Given this list of marker genes IL27RA, MRPS25 (mitochondrial ribosomal protein S25), EXT2, VPS36, DACH2, NARF, ST3GAL1, CRNKL1 (crooked neck pre-mRNA splicing factor 1), DHX29, PPME1, DCUN1D2, ETV6, SYT11, CSK, SYS1, ZNF280D, CXCR3, PRKAR2A, CORO1A, ARHGEF6, CNN2, VWA5A, ARF1, PAFAH2 (platelet activating factor acetylhydrolase 2), SENP7, CYP11A1, CTSC (NCBI Gene Id 50958), RAB4B, PSMD6, ROMO1, HOPX, ARHGAP29, SRSF7, FGGY, BCCIP, PPP2R5A, COX17, TMEM158, EI24, GNG2, CTSD (cathepsin D), GIMAP7 (NCBI Gene Id 168537), MAPK11, DNAH8, CLDND1, INPP5B, PSMA3, GGT1, S100A6, HIC1, MCTP2, TLR1, ADCY6, HYPK, GPM6B, ENTR1, TALDO1, ZFP36L1, MRPL51 (mitochondrial ribosomal protein L51), STAT1, BBLN, TRIB2, POU2AF1, GTF3C6, SPICE1, ECSIT, CTSW, UQCC2, ELAVL1, ATXN7L3B, ATP2A2, ECM1, FAM78A, PICALM, MRPL52, PFN1, FOXO4, DNAJA1, TMEM238, ECH1 (enoyl-CoA hydratase 1), TOP1, ATP6V1H, ITPKB, PRPF38B, HACD1, CDC42EP3, DBNL, GPSM3, KPNA2, METTL3, TRPV2, ARPC5L, HDAC6 (NCBI Gene Id 100820762), FAM98A, DMTF1, TPRG1L, PNN, VPS45, SCAMP3, MGRN1, ACTN1, SLCO4A1, RFK, GATD3, NISCH, SSNA1, CETN3, TUBB4B, RRAS2, GBA1, RPS6KA1, PKP3, SELPLG, SRSF6, KDM5C, EDEM3, HSDL2, ATG3, ERH, PPDPF, HMMR, GALNT6, CIC, HECTD3, CEP55, ULK2, GRAMD4, BICD2, NEAT1, RASSF2, ITGB1BP1, ESYT1, DSTN, TNFRSF1A, KBTBD11, UBA1, FAM120B, ZNF207, MRS2, PIGQ, PSD4, GLRX2, NDRG3, UBL4A, SLA, SIPA1L1, APP, SMARCD2 (SWI/SNF related, matrix associated, actin dependent regulator of chromatin, subfamily d, member 2), NEMF, TRAF5, PDIA6, SUGT1, SSBP4, RBX1, NXF1, DNAJB11, ENTPD5, SMAP2, CYB5A, S100A11, MTCH2, THY1 (Thy-1 cell surface antigen), SLC30A5, CYB561A3, PLAC8, CHD3, EXOSC8, XPO1, MTF2, MID1IP1 (NCBI Gene Id 58526), SOAT1, STIP1, GDI1, GPR132, AP4S1, ZNF467, CDC23, SLC30A4, TMEM126A, L1CAM, PROS1, TGFB3, VSIR, RFX1, EMG1, MTREX, TIA1, MRPS21, IL12RB2, LAMA5, ANXA5, HSPA1B (heat shock protein family A (Hsp70) member 1B), CCR5, TMEM147, NKG7, PTPRCAP, GRB2, KCNN4, AKT2, CDR2, here is a description of the gene set: Human Gene Set: GSE22601_IMMATURE_CD4_SINGLE_POSITIVE_VS_CD4_SINGLE_POSITIVE_THYMOCYTE_UP Genes up-regulated in CD4 single positive cells: immature versus thymocytes. T cells develop from progenitors that migrate from the bone marrow into the thymus. Thymocytes are subdivided roughly as being double negative (DN), double positive (DP), or single positive (SP), based on the expression of the CD4 and CD8 coreceptors. The DN stage is heterogeneous and can be subdivided into four distinct subsets in mice based on the expression of CD44 and CD25. In human, three distinct DN stages can be recognized: a CD34+CD38−CD1a− stage that represents the most immature thymic subset and the consecutive CD34+CD38+CD1a− and CD34+CD38+CD1a+ stages. Human DN thymocytes mature via an immature single positive (ISP CD4+) and a DP stage into CD4+ or CD8+ SP T cells that express functional T cell receptors (TCR) and that exit the thymus. In this study, gene expression was measured in each of these nine stages. from publication Dik WA, Pike-Overzet K, Weerkamp F, de Ridder D, de Haas EF, Baert MR, van der Spek P, Koster EE, Reinders MJ, van Dongen JJ, Langerak AW, Staal FJ (PMID 15928199) studied in species Homo sapiens